Given this list of marker genes CYBB, PSMB4, PSMC2, COX8C, CDKN2A, SIN3B, PSMC4, EP300, GPX1, ATP7A, COX4I2, ALB, BTRC, BCL2, HM13, AKT3, SESN1, COX6C, PRDX5, NCF1, VCP, SQSTM1, MT-CO2, MT-CO3, PSMD2, STAT3, PSMD1, COX4I1, MYC (MYC proto-oncogene, bHLH transcription factor), PSMB2, NCF2, AKT1, CYBA, HBB, PSMD6, BACH1 (BTB domain and CNC homolog 1), EGF, MAP1LC3B, TXNRD2, MAFK, SOD1, PSMA1, MT-CO1, CREBBP, UBB, SESN2, SRXN1, GCLM, RPS27A, HIGD1C, PSMD12, PSMA3 (NCBI Gene Id 5684), CDKN1A, GPX7, GSTA3, AKT2, PSMD13, NCOR1, PRDX2, PRKCI, PSMA2, COX7C, SOD2 (superoxide dismutase 2), CAT, COX6B1 (cytochrome c oxidase subunit 6B1), IDH1, PSMA6, GSTA1, ATF4, COX5A, GPX5, PSMC3, UBC, HMOX2, HBA1, PSMA7, DPP3, PTK6, RXRA, TRIM21, GPX2, MIRLET7C, ABCG2, UBA52, GPX6, RBX1, PRDX1, MIR196A1, PDGFA, CHD9, NCOR2, COX5B, ATOX1, STAP2, NQO1, NCF4, PSMA5, ADRM1, PALB2, TKT, SEM1, COX7A1, PSMD3, TXN2, TXNRD1, CUL1, PGD, CSNK2A2, IL8, GSK3B, CYCS, BLVRB, COXFA4, PRKAA2, FBXL17, MED1, COX8A, SLC7A11, PRDX6, SP1, HELZ2, PSMC5, PSMA4, SIN3A (NCBI Gene Id 25942), ME1, KEAP1, NOX5, X, GCLC, PSMB7, CCL2 (C-C motif chemokine ligand 2), CCS, MIR98, COX7A2, COX7A2L, TALDO1, CSNK2B, PPARA, ERO1A, TXN, MUL1, ABCC3, PSMD11, AQP8, NCOA6, MIR155, PSMD14, EIF2AK3, PSMB5, NFKB1, UBXN7, TBL1X, MAFG, NCOA2 (nuclear receptor coactivator 2), BCL2L1, PSMD7, ABCF2, PSMB6, PSMB3, TBL1XR1, TXNIP, COX6A1, PSMD8, ABCC1, GSR, HDAC3, SKP1, UFD1, AREG, PSMB1, P4HB, CHD6, PRDX3, PSMC1, NPLOC4, COX6A2, MIRLET7B, AMER1 (NCBI Gene Id 160176), CSNK2A1, PSMC6, GPX3, HMOX1, CARM1, SOD3, NCOA1, NUDT2, COX7B, PRKCD, BRCA1, NFE2L2, SMARCD3, G6PD, NLRP3, RELA, SKP2, NOX4, FABP1, BLVRA, TGS1 (NCBI Gene Id 96764), GPX8, COX6B2, CUL3, GSTP1, NOTCH1, here is a description of the gene set: part of: Cellular responses to stress Reactome Pathway: Cellular response to chemical stress Cells are equipped with versatile physiological stress responses to prevent hazardous consequences resulting from exposure to chemical insults of endogenous and exogenous origin. Even at equitoxic doses, different stressors induce distinctive and complex signaling cascades. The responses typically follow cell perturbations at the subcellular organelle level.<br><br>Expression of heme oxygenase 1 (HMOX1) is regulated by various indicators of cell stress. Cytoprotection by HMOX1 is exerted directly by HMOX1 and by the antioxidant metabolites it produces through the degradation of heme.<br><br>Reactive oxygen and nitrogen species (RONS) are important mediators of chemical stress, as they are produced endogenously in mitochondria, and also result from redox activities of many toxins and heavy metal cations. The points of RONS action in the cell are plasma and ER membrane lipids, as well as DNA, both acting as sensors for the cellular response. On the other hand, chemotherapeutic agents exert their action via generation of RONS and induction of cancer cell apoptosis, while drug resistance associates with RONS-induced cancer cell survival. studied in species Homo sapiens